Given this list of marker genes AKAP9, CDH5 (cadherin 5), NME7, DYRK1A, GBA2, PPP2CA, HAUS3, FKBP4, HAUS2, MET, SLAIN2, EML2, CLIP1, MAPRE3, CAV3, HAUS4, ANKRD53, CKAP5, PRUNE1, MAP2, OCLN, PAK1, TUBB4A, HAUS1, STMN1, DCTN1, CLASP1, KIF21A, PPP2CB, HSPA1B, HAUS8, STMN2, CAMSAP2, CDK5RAP2, HAUS5, CLASP2, CDK5R1, CLIP3, NUMA1, HAUS7, TOGARAM1, TBCD, NAV3, SKA1, GIT1, INPP5J, MECP2, MAPRE1, ARL2, DRG1 (NCBI Gene Id 4733), MAP1B, PSRC1, PDE4DIP, CAMSAP3, HAUS6, SNCA, SLAIN1, FES, CDKN1B, SLC39A12, RAC1, CAMSAP1, RPS3, HSPA1A, MAPT, ABL1, ARHGEF7, here is a description of the gene set: Any process that modulates the frequency, rate or extent of microtubule polymerization. species: Homo sapiens Human Gene Set: GOBP_REGULATION_OF_MICROTUBULE_POLYMERIZATION